Given this list of marker genes REG1A, PDIA2, CELA3B, AQP8, HNF1B (NCBI Gene Id 6928), GNMT, RNASE1, CTRC, CPB1, PTF1A, ONECUT1 (one cut homeobox 1), KLK1, PLA2G1B, CELA2A, PDX1, PRSS1, BHLHA15, SPINK1, CPA2, PNLIP (NCBI Gene Id 5406), CTRL, GP2, SERPINA4, GATA4, CEL, SOX9, PNLIPRP2, SYCN (NCBI Gene Id 342898), FOXA2, AMY2A, NKX6-1, CPA1, here is a description of the gene set: species: Homo sapiens Human Gene Set: REACTOME_DEVELOPMENTAL_LINEAGE_OF_PANCREATIC_ACINAR_CELLS Developmental Lineage of Pancreatic Acinar Cells